The following is a description of a gene set: The process in which a relatively unspecialized cell acquires specialized features of a satellite cell. species: Homo sapiens Human Gene Set: GOBP_SKELETAL_MUSCLE_SATELLITE_CELL_DIFFERENTIATION, and this is the list of marker genes: KAT8, SIX4, MYLK2, CDON, AKIRIN1, EPHB1, MEGF10, PAX7, KLF5, SELENON, MSTN, SIRT2, MCUB